The following is a description of a gene set: An abnormal increase (delay) in the conduction time of the brainstem auditory-evoked response. Human Gene Set: HP_DELAYED_BRAINSTEM_AUDITORY_EVOKED_RESPONSE_CONDUCTION_TIME Delayed brainstem auditory evoked response conduction time studied in species Homo sapiens, and this is the list of marker genes: HYCC1 (NCBI Gene Id 84668), SH3TC2 (SH3 domain and tetratricopeptide repeats 2), HIKESHI, GALC, PSAP